Given this list of marker genes MBD2, HMGA2, EHMT1, TAF9, GATA1, WT1, LEF1, ZXDC, U2AF2, THAP7, ZXDA, GATA2, EHMT2, SRRM2, here is a description of the gene set: Binding to a C2H2-type zinc finger domain of a protein. The C2H2 zinc finger is the classical zinc finger domain, in which two conserved cysteines and histidines co-ordinate a zinc ion. studied in species Homo sapiens Human Gene Set: GOMF_C2H2_ZINC_FINGER_DOMAIN_BINDING